Given this list of marker genes TERF2IP, MARCKSL1, INA, TUBA1A, NHLH1, KLC1, FSTL5, SPOCK2 (SPARC (osteonectin), cwcv and kazal like domains proteoglycan 2), BEX1, ATF5, KIF5C, RUNDC3A, EPB41, HRK, EFNA5, EEF1A2, SCG3, MAPK10, RAB6A, TPPP3, PSIP1, BCL11B, GNB2 (G protein subunit beta 2), SSBP2, SYT11, GTF2I, NSG1, CALM1, PCLO, NRXN1, RETREG1, IFT27, PLEKHB1, STMN4, TUBB, DCLK1, CCNI, CARTPT (NCBI Gene Id 9607), FZD3 (frizzled class receptor 3), CDKN2D, CALB2, NCAM1, MARCKS, SPOCK1, SDC3, EBF2, RGMB, CASP3, SERPINE2, UCHL1, SNCA, JPT1, NHLH2, PPA1, PAPOLA, KIFAP3, PCDH9, CCDC184, CKB, OLIG2, TMPRSS6, GDAP1, INSM1, KIF3A, CRMP1, PRRC2B, EBF4, STMN3, H2BC21 (NCBI Gene Id 8349), EFNA3, TRIM66, APLP1, BASP1, SOX11, ELAVL4, CENPV, MAP6, SYT1, DCX, GFY, MYT1L, MSI2, PCSK1N, ARMH4, CADM1, RUFY3, KCNQ1OT1, EBF3, CNTN4, SCN9A, PODXL2, APBB1, STMN1, NBEA, MAP1B, GNG8, CEBPG, CBX4, RTP1, DPYSL3, CADPS, EPCAM, EMX2, PDAP1, GDI1, RTN1, ELAVL3, NICOL1, EFHD1, GAP43, KSR2, DPYSL2, PAFAH1B3, CAPS, EFR3B, VAMP2, NLRP1, CLGN, EFHC1, SCG5, FAM131C, GNB1, RTN3, DAAM1, CALM2, TRIB3, TUBB2B, RNF182 (ring finger protein 182), FAM171B, FXYD6, SYT5, EBF1, RFK, GDE1, TUBB2A (NCBI Gene Id 92919), KIF1A, TTLL7, STMN2, LHX2, THUMPD3-AS1, here is a description of the gene set: from publication Durante MA, Kurtenbach S, Sargi ZB, Harbour JW, Choi R, Kurtenbach S, Goss GM, Matsunami H, Goldstein BJ (PMID 32066986) Human Gene Set: DURANTE_ADULT_OLFACTORY_NEUROEPITHELIUM_IMMATURE_NEURONS species: Homo sapiens